Given this list of marker genes Map2k7, Nek2, Mapk1, Potefam3a, Mapkapk5, Map3k4, Pkib, Rtel1, Mapk15, Ankrd66, Pnkp, Tnks, Mapk3, Tnks2, Aurkb, Potefam3b, Prkcq, Nek7, Nabp2, Hnrnpd (NCBI Gene Id 330135), here is a description of the gene set: Any process that activates or increases the frequency, rate or extent of telomere capping. studied in species Mus musculus Mouse Gene Set: GOBP_POSITIVE_REGULATION_OF_TELOMERE_CAPPING